The following is a description of a gene set: studied in species Homo sapiens Hypoplasia of the vagina Developmental hypoplasia of the vagina. Human Gene Set: HP_HYPOPLASIA_OF_THE_VAGINA, and this is the list of marker genes: GATA4, B3GLCT, CYP17A1, SRY, DHX37, CYP11B1, ZFPM2, SOX9, NR0B1, WT1, CYB5A, VAMP7, WWOX, MAP3K1, NR5A1 (nuclear receptor subfamily 5 group A member 1), IRF6